Given this list of marker genes SFRP1, DKK4, KREMEN1, WNT3A, SOST, SFRP2, LRP6, WNT4, WNT9A, KREMEN2, WIF1, DKK2, DKK1, LRP5, WNT5A, here is a description of the gene set: studied in species Homo sapiens Several unrelated families of secreted proteins antagonize WNT signaling. Secreted frizzled-related proteins (sFRPs) have a cysteine rich domain (CRD) that is also found in FZD and ROR receptors, while WNT inhibitory factor (WIF) proteins contain a WIF domain also present in the WNT-receptor RYK. Both these classes of secreted WNT antagonists inhibit signaling by binding to WNTs and preventing their interaction with the FZD receptors. sFRPs may also able to bind the receptors, blocking ligand binding. The interaction of WIF and sFRPs with WNT ligand may also play a role in regulating WNT diffusion and gradient formation.<br><br>Dickkopf (DKK) and Sclerostin (SOST) family members, in contrast, antagonize WNT signaling by binding to LRP5/6. There are four DKK family members in vertebrates; the closely related DKK1, 2 and 4 proteins have been shown to have roles in WNT signaling, while the more divergent DKK3 appears not to. Secreted DKK proteins bind to LRP6 in conjunction with the single-pass transmembrane proteins Kremen 1 and 2, and this interaction is thought to disrupt the WNT-induced FZD-LRP5/6 complex. In some cases, DKK2 has also been shown to function as a WNT agonist. <br>Like DKK proteins, SOST binds LRP5/6 and disrupts WNT-dependent receptor activation. part of: TCF dependent signaling in response to WNT Reactome Pathway: Negative regulation of TCF-dependent signaling by WNT ligand antagonists